Given this list of marker genes Gpr22, 6030468B19Rik, Nup58, Arl5b, Dicer1, Ier2, Kif18a, Etv3, Crtac1, Tmtc4, Gadd45g, Tmem86a, Mir670hg, Opn3, Slc12a3, Klf9, Nptx1, Galnt18, Arc, Shisa2, Lmo2, Skp2, Itprip, Slc4a7, Hycc2, Errfi1, Ier5 (NCBI Gene Id 15939), Dctn6, Cpne7, Kcnip2, Rgs4, Homer1, Gpr4, Mir9-2hg, Itpka, Wipf3, Zfp275, Guk1, Pxdn, Oip5os1, Glce, Rab40b, Vgf, Bdnf, Egr1 (NCBI Gene Id 13653), Nptx2, Crhbp, Sv2b, Trmt10b, Osgin2, Sertad1, Elavl4, Kcna4, Kcna1, Egr4, Hpca, Egr3, Tesc, Hsd11b1 (hydroxysteroid 11-beta dehydrogenase 1), Fhl2, Ddi2, Krtap4-7, Sorcs3, Arpp21, Egr2, Septin8, Mlip, Tlcd4, Fam131a, Ybx3, Wdr77, Fam210b, here is a description of the gene set: Neuronal activity regulates the development and maturation of excitatory and inhibitory synapses in the mammalian brain. Several recent studies have identified signalling networks within neurons that control excitatory synapse development. However, less is known about the molecular mechanisms that regulate the activity-dependent development of GABA (gamma-aminobutyric acid)-releasing inhibitory synapses. Here we report the identification of a transcription factor, Npas4, that plays a role in the development of inhibitory synapses by regulating the expression of activity-dependent genes, which in turn control the number of GABA-releasing synapses that form on excitatory neurons. These findings demonstrate that the activity-dependent gene program regulates inhibitory synapse development, and suggest a new role for this program in controlling the homeostatic balance between synaptic excitation and inhibition. from publication Lin Y, Bloodgood BL, Hauser JL, Lapan AD, Koon AC, Kim TK, Hu LS, Malik AN, Greenberg ME (PMID 18815592) Mouse Gene Set: LIN_NPAS4_TARGETS_DN Genes down-regulated in neurons after NPAS4 knockdown by RNAi. species: Mus musculus